The following is a description of a gene set: species: Homo sapiens Human Gene Set: MORF_RAC1 Neighborhood of RAC1 Neighborhood of RAC1 ras-related C3 botulinum toxin substrate 1 (rho family, small GTP binding protein Rac1) in the MORF expression compendium, and this is the list of marker genes: PIGC, MTDH, ACTL6A, ANKRD17, COX5A, ATXN2, HSPA8, CYC1, RBCK1, CFDP1, TMED2, SEC61B, ARCN1, SDHA, PEX11B (NCBI Gene Id 8799), DDB1 (damage specific DNA binding protein 1), DYNC1I2, SNX1, MTCP1 (mature T cell proliferation 1), GPX4, GMFB, RAC1, TMEM106C, RAN, RAF1, PWP1, METAP1, NSDHL, ATOX1, ATP2A2, IST1, PSMC2, BRD8, ZNRD2, UBR5, ATP6V1F, CS, BCAP31, CRK (CRK proto-oncogene, adaptor protein), CSNK1G2, COA1, XPC (NCBI Gene Id 7508), UBE2A, MORF4L2 (mortality factor 4 like 2), RNF4 (ring finger protein 4), ATP6V1H, CENPB, POLR3C, GPAA1, ZZZ3, NUP62, ATP6V0D1, GANAB, COX6A1, RPA1, DNPEP, SDHC, MAML1, SNAPC5, RAD23B, TRAPPC3, FOXK2, POLR2I, YIF1A, SUMO2, HTATSF1, UBAP2L, NDUFC1, UBA1, SSR4 (signal sequence receptor subunit 4), PSMD7, POLR2C, ATG12, COX7A2L, HADHB, KDELR1, PPP1R7, KARS1, PHF3, DOCK3, SMARCD2, JTB, PSMB2, SP3, SARS1, SOD1, CAPZB, SEC24C, VGLL4, RAB5A, VPS26A, STK24, DCTN2, RTN4, TMEM147, MEA1, PRKAR1A, F8A1, COX8A, SART3, OTUB1, AP3S1, PSMB4, FBXW11, CNOT3, PPP2R5E, ARF3, EBAG9, GFUS, FAM120A, PRPSAP1, PSMB6, KHDRBS1, MAP2K2, EI24, PMM2, IDH3G, NCBP2, MYL11, AP2M1, PRDX4, CSNK2B, PCBD1, SKP1, SLC4A2, TMBIM6, PDAP1, ARF4, CYCS, PARG, MDH1, TIAL1, COPS7A, CDK16, ARFGEF1, MRPL9, STARD7, MTA1, PLOD3, PRKAG1, CTDNEP1, SMNDC1, MRPL28, SHMT1, ATP6AP1, CLTC, SEPHS2, SLC10A3, NONO, KXD1, ENSA, PSMD8, HNRNPAB, SYPL1, CNIH1, ARPC5, WBP2, COPS5, ILVBL, ATP5MF, GLG1, EIF2B2, RAD21, STX4, ARF5, RAB6A, SRP9, GGCT, SPCS2, UBE3C, PPP1R11, XPO6, EML2, MRPS18B, PPT1, SNRNP200, SEC61G, C6orf62, DRG1, TMED9, COPB2, PICALM, RHEB, PDCD6, GORASP2, DAP, GLB1, RTCB, PGRMC1, DPM1, SUMO1, LYPLA1, XPO7, CLN3, ACTN4, BLOC1S1, AHCYL1, SEM1 (SEM1 26S proteasome subunit), HNRNPA2B1, ISCU, YWHAB, RAB5B, CANX, BANF1, RAB1A (NCBI Gene Id 5861), AP2S1, NIPSNAP1, PPP2R1A, ABR, FMR1, SEC13, SERP1